Given this list of marker genes Tekt3, Sts, Nlrp5, Adra2a, Gip, Cfc1, P2rx1, Adm, Tgfbr1, Smcp, Fbln1, Ucn, Tekt4, Ints1, Med1, Mtor (mechanistic target of rapamycin kinase), Prl2c3, Il11ra3, Tacr1 (tachykinin receptor 1), Pla2g4a, Prss29, Slc2a1, Itga5, Ghrl, Lgals9, Ndrg3, Bmal1, Polr1b, Prl8a1, Acr, Pappa, Atr, Lif, Kiss1, Mirlet7c-2, Gm773, Ndp, Adcy7 (NCBI Gene Id 11513), Ptn, Svs3a (NCBI Gene Id 99449), Tead4, Gja1, Junb, Hpgd, Cdh1, Cd38, Dedd, Hmx3, Klk14, Tle6, Cbs, Prl4a1, Pithd1, Mirlet7a-2, Ghsr, Thbd, Prl5a1, Serpine2, Endou, Timp1, Men1, Nrk, Abcg2, Esr1, Tgm4, Oxtr, Fut7 (NCBI Gene Id 99110), Sp1, Psg22, Adipor2, Prl3a1, Pcsk5, Bmpr2, Prl7d1, Bsg, Nr2f2, Stox2 (NCBI Gene Id 71069), Cuzd1, Prl3b1, Rara, Smurf2, Prl, Klf9, Hyal5, Vdr, Crh, Mug1, Trim28, Acvr1b, Hspe1-rs1, Mir26a-1, Hsd11b2, Arhgdib, Acsl4, Dsg2, Fos, H2-Q2, Prl6a1, Stat5a, Garin5b, Angpt2 (NCBI Gene Id 11601), Agrp (agouti related neuropeptide), Ctsb, Il11ra2, Ooep, Epn1, Slc38a2, Igfbp2, Cad, Mirlet7c-1, Exoc1, Cnr1, Prl7a2, Rxfp1 (NCBI Gene Id 387561), Mmp9, Ggn, Aplf (aprataxin and PNKP like factor), Errfi1, B4galt1, Vegfa, Sod1, Prl7a1, Mir143, Ube2a, Grn, Garin5a, Mapk3, Ago2, Syde1, Fosl1 (NCBI Gene Id 14283), Comt (catechol-O-methyltransferase), Prl8a8, Adra2b, Gh, Acod1, Rxra, A1cf, Cited2, Mmp2, Ccl2, Ash1l, Oprm1, Prdm14, Prl3d2, Tcf23, Prl7c1, Emp2, Calr, Prss28, Stat5b, Havcr2, Ctsl, Dkkl1, Arid1a, Crhbp, Hfe, Reck, C1qbp, Stx2, Prl8a6, H3f3b, Ace2, Prl3d1, Lamb1, Cldn4, Prdm1, Oxt, Garin3, Ddr1, Ppard, Sh3pxd2b, Ar, Adra2c, Stc2, Ppp3cc, Apela, Mst1, Akt1, Stc1, Prl3c1, Pgr, Prl8a2, Pzp, Parp1, H2-Q7, Wnt4, Prl2c1, Itgb4, Ace, Prl2c2, Tnp2, Kpna6, Fkbp4, Ptgis, Kalrn, T, Mmp12, Zscan4a, Slc6a4, Prl2c5 (NCBI Gene Id 53971), Nodal, Lep, Nppa, Psg17, Acvr2a (NCBI Gene Id 11480), Garin2, Rgs2, Umps (NCBI Gene Id 73572), Ubtfl1, Gjb2, Prl3d3, Vmp1, Ihh, Mir21a, Hexb, Ldoc1, Mir20a, Dazap1, Akr1c18, Cr1l, Itga2, Acvr1c, Cyp27b1, Avpr1a, Il11ra1, Capn2, Parp2, Ptgs2, Smad3 (SMAD family member 3), A2m, Prdx3, Itgb3, Hsf1, Itga3, Mirlet7b, Fosb, Mirlet7a-1, Garin4, Maged2 (NCBI Gene Id 80884), Ddo (NCBI Gene Id 78278), Slc38a3, Sult1e1, Corin, Tgfb1, Slc38a1, Epor, Prl7b1, Csmd1, Prl2a1, Mir26a-2, Mirlet7d, Ppp3r2, Rxrb, Cyp1a1, Fbn2 (fibrillin 2), Uprt, Zscan4b, Ube2q1, Slc19a1, Sp3, Edn1, Prl8a9, Epo, Ptafr, Dcaf13, Ythdf3, Mapk1, Hyal3, Prl2b1, Smad2, Sphk2, Abcb1a, Tppp3, Igfbp5, Tmed2, here is a description of the gene set: Mouse Gene Set: GOBP_MULTI_MULTICELLULAR_ORGANISM_PROCESS studied in species Mus musculus A multicellular organism process which involves another multicellular organism of the same or different species.